The following is a description of a gene set: studied in species Homo sapiens Human Gene Set: GOBP_MITOCHONDRION_LOCALIZATION Any process in which a mitochondrion or mitochondria are transported to, and/or maintained in, a specific location within the cell., and this is the list of marker genes: ZBED3, MARK1, BHLHA15, MAP1S, PLIN5 (NCBI Gene Id 440503, perilipin 5), HIF1A, FEZ1, MARK2, TRAK1, SLC4A5, HSBP1, KIF5B, MYO19, HDAC6, UCHL1, MEF2A, KIFBP, NECTIN2, PKD1, LRRK2, RHOT1, MAPT, MTM1, MUL1, TRAK2, MAP1B, NEFL, SYBU, MGARP, OPA1, PRKN, DNM1L, RHOT2, UBB, TSPAN9, MFN1, ARMCX3, BRAT1, AGTPBP1, HAP1, SPAST, KIF1B, ACTR10, MFN2, LRPPRC, KAT2A, EPCIP, UXT, TLE6 (NCBI Gene Id 84846), ARMC1, AGBL4, WASF1, ATP2A1, ATCAY, MSTO1, CLUH